The following is a description of a gene set: Any process that activates or increases the frequency, rate or extent of potassium ion import across the plasma membrane. Human Gene Set: GOBP_POSITIVE_REGULATION_OF_POTASSIUM_ION_IMPORT_ACROSS_PLASMA_MEMBRANE species: Homo sapiens, and this is the list of marker genes: ANK2, STK39, ATP1B1, ATP1B2, ATP1B3